The following is a description of a gene set: studied in species Homo sapiens Binding to a hemoglobin alpha chain. Human Gene Set: GOMF_HEMOGLOBIN_ALPHA_BINDING, and this is the list of marker genes: HBD, HBB, HBE1, HBG2, HBG1